The following is a description of a gene set: species: Homo sapiens Any process that modulates the rate, frequency or extent of the assembly, arrangement of constituent parts, or disassembly of the microtubule spindle. Human Gene Set: GOBP_REGULATION_OF_SPINDLE_ORGANIZATION, and this is the list of marker genes: PSRC1, CHMP4B, GNAI1, MAPK15, DRG1, HNRNPU, CEP97, CHMP1A, GPSM2, SASS6, NUMA1, NUP62, CHMP3, SPAG5, CLTC, FSD1, PLK1, CHMP4C, TACC3, CHMP2A, CHMP4A, HSPA1B, DYNC1H1, MAP9, BORA, ANKRD53, PKD1, CHMP2B, EML3, RNF4, RIPOR2, SENP6, DCTN1, CHMP4BP1, TPR (translocated promoter region, nuclear basket protein), CHMP6, CENPJ, RAE1, HSPA1A, CHMP1B (NCBI Gene Id 57132), CCSAP, TPX2, CHMP5, CHMP7, RCC1, STIL, VPS4B, PDCD6IP, PARP3